Given this list of marker genes RFC1, RPA2, USP1, RPA3, UBE2B, RAD18, POLD1, RFC2, RFC4, RPA1, UBC, WDR48, CUL4A, RPS27A, POLD3 (DNA polymerase delta 3, accessory subunit), POLD2, POLD4, POLE3, PCNA, UBB, POLE, CUL4B, RFC3, UBA52, POLE4, RFC5, POLE2, DTL, RBX1 (NCBI Gene Id 9978), DDB1, here is a description of the gene set: part of: DNA Damage Bypass Damaged double strand DNA (dsDNA) cannot be successfully used as a template by replicative DNA polymerase delta (POLD) and epsilon (POLE) complexes. When the replication complex composed of PCNA, RPA, RFC and POLD or POLE stalls at a DNA damage site, PCNA becomes monoubiquitinated by RAD18 bound to UBE2B (RAD6). POLD or POLE dissociate from monoubiquitinated PCNA, while Y family DNA polymerases - REV1, POLH (DNA polymerase eta), POLK (DNA polymerase kappa) and POLI (DNA polymerase iota) - bind monoubiquitinated PCNA through their ubiquitin binding and PCNA binding motifs, resulting in a polymerase switch and initiation of translesion synthesis (TLS). Reactome Pathway: Recognition of DNA damage by PCNA-containing replication complex species: Homo sapiens